Given this list of marker genes AGO3, MIR449A, ATP2A1, MAML2, NOTCH2, NOTCH2NLA, MAML1, TFDP1, NOTCH2NLC (notch 2 N-terminal like C), H2AC6, TNRC6B, H2BC12L, H2BC14, PRKCI (NCBI Gene Id 5584), AGO2, MIR206, H2BC5, H2AC18, SEL1L, MIR181C, MFNG, NOTCH1, ELF3, H2AZ2, NOTCH4, H4C1, SIRT6, MIR302A, MIR34B, H2BC26, MOV10, SNW1, H2BC15, H3-3A, H2BC13 (H2B clustered histone 13), H2BC12, ST3GAL4, JUN, NOTCH2NLB, ATP2A3, FURIN, CCND1, H2AC20, H2AB1, EP300, KAT2B, H2AJ, RBPJ, H2BC4, TP53, RAB6A, AGO4, LFNG, MAMLD1 (mastermind like domain containing 1), H2BC17 (H2B clustered histone 17), POFUT1, MAML3, H2AX, RUNX1 (RUNX family transcription factor 1), CREBBP, H2AC14, RFNG (RFNG O-fucosylpeptide 3-beta-N-acetylglucosaminyltransferase), H2BC21, E2F1, POGLUT1, H2BC11, MIR150, ELANE, B4GALT1, ATP2A2, H2AC4, MIR200B, TFDP2, MIR34A, H2BC1, MIR449C, ST3GAL3, NOTCH2NLR, TNRC6C, MIR449B, H2BC9 (NCBI Gene Id 8345, H2B clustered histone 9), H3C15, H2AC7, H3C1, ST3GAL6, E2F3, TNRC6A, KAT2A, AGO1, H2BC3, MIR200C, MIR34C, NOTCH3, TMED2, here is a description of the gene set: studied in species Homo sapiens Reactome Pathway: Pre-NOTCH Expression and Processing part of: Signaling by NOTCH In humans and other mammals the NOTCH gene family has four members, NOTCH1, NOTCH2, NOTCH3 and NOTCH4, encoded on four different chromosomes. Their transcription is developmentally regulated and tissue specific, but very little information exists on molecular mechanisms of transcriptional regulation. Translation of NOTCH mRNAs is negatively regulated by a number of recently discovered microRNAs. <br><br> The nascent forms of NOTCH precursors, Pre-NOTCH1, Pre-NOTCH2, Pre-NOTCH3 and Pre-NOTCH4, undergo extensive posttranslational modifications in the endoplasmic reticulum and Golgi apparatus to become functional. In the endoplasmic reticulum, conserved serine and threonine residues in the EGF repeats of NOTCH extracellular domain are fucosylated and glucosylated by POFUT1 and POGLUT1, respectively. <br><br> In the Golgi apparatus, fucose groups attached to NOTCH EGF repeats can be elongated by additional glycosylation steps initiated by fringe enzymes. Fringe-mediated modification modulates NOTCH signaling but is not an obligatory step in Pre-NOTCH processing. Typically, processing of Pre-NOTCH in the Golgi involves cleavage by FURIN convertase. The cleavage of NOTCH results in formation of mature NOTCH heterodimers that consist of NOTCH extracellular domain (NEC i.e. NECD) and NOTCH transmembrane and intracellular domain (NTM i.e. NTMICD). NOTCH heterodimers translocate to the cell surface where they function in cell to cell signaling.